Given this list of marker genes Htr1f, Ghdc, Gm20485, Tmem51os1, Ggt5, Zic1, Slc6a12, Flrt2, Angptl4, Ccr9, Dock5 (dedicator of cytokinesis 5), Pdgfrl, Ptgfr, Epha7, Arhgap20, Gm42397, Lum, Aebp1 (AE binding protein 1), Pi15, Pdgfrb, Ankrd55, Kcnt2, Gm17501, Slc1a3, Gm11837, Atp13a5, Il6st, Itgbl1, Cthrc1, Adra2a, Ifi27, Gm12098, Lepr, Cldn11, Cyp1b1, Lrrk2, Gm15958, Atp1a2, Tmtc4, Ptchd4, Zic2, Plekhh3, Syt12, Colec12, Arhgap20os, Slc22a6, Mill2, Alcam, Apod, Mkx, Gm5127, Fmo1, Adamts12, Fam118a, C230034O21Rik, Mro, Slc7a11, Bgn, Rgs5, Ranbp3l, Gm6209, Gm17473, Nkd1, Ddx43, Gm15270, Mageb18, 9530046B11Rik, Gmds, Sidt1, Itga11, Lamc3, Polm, 4930594M22Rik (RIKEN cDNA 4930594M22 gene), Zpld1, Gm12829, Slc6a20a, Gm32531, Akap12, here is a description of the gene set: species: Mus musculus from publication Cao J, Spielmann M, Qiu X, Huang X, Ibrahim DM, Hill AJ, Zhang F, Mundlos S, Christiansen L, Steemers FJ, Trapnell C, Shendure J (PMID 30787437) Mouse Organogenesis Cell Atlas (MOCA) DE_gene_main_cluster.csv, fold.change>=1.5, qval<0.05, pval<0.05 Mouse Gene Set: DESCARTES_ORGANOGENESIS_CHONDROCYTE_PROGENITORS